Given this list of marker genes DFFA, LMNB1, CLSPN, CTNNB1, STK26, CASP6 (NCBI Gene Id 839), PRKCD, CASP8, DBNL, DFFB, DSG3, GAS2, H1-4 (H1.4 linker histone, cluster member), DNM1L, CDH1, SATB1, DSG1, PLEC, ADD1, H1-3, FNTA, SPTAN1, H1-5, DSG2, KPNA1, ROCK1, DSP, KPNB1, BIRC2, ACIN1, MAPT, H1-2, TJP2, H1-1, BCAP31 (NCBI Gene Id 10134), STK24, PKP1, APC, VIM, PRKCQ, CASP3, CASP7, OCLN, H1-0, LMNA, GSN, HMGB1, HMGB2, BMX, PAK2, TJP1, PTK2, here is a description of the gene set: part of: Apoptosis In the execution phase of apoptosis, effector caspases cleave vital cellular proteins leading to the morphological changes that characterize apoptosis. These changes include destruction of the nucleus and other organelles, DNA fragmentation, chromatin condensation, cell shrinkage and cell detachment and membrane blebbing. studied in species Homo sapiens Reactome Pathway: Apoptotic execution phase